The following is a description of a gene set: Genes predicted to be targets of miRBase v22 microRNA hsa-miR-6783-5p in miRDB v6.0 with MirTarget v4 prediction scores > 80 (high confidence targets). from publication Chen Y, Wang X (PMID 31504780) Human Gene Set: MIR6783_5P species: Homo sapiens, and this is the list of marker genes: COL5A2, CSRNP2, PCDHA13, CEP162 (centrosomal protein 162), ASAP1, PCDHA5, RNF34, SLC45A3, PCDHA10, ARL3, PCDHA8, CCL2, IPO8, ZMYM4 (zinc finger MYM-type containing 4), GLYATL3, DLK1, KCNIP2, DGKA, ZNF483, SLC17A7, CADM2, CRABP1, ARRB1, STAU2, NTRK2, KIF21B, MID2, L3MBTL1, ZFAND1, PYGO2, APLP1, PCDHA6, POGZ, PTCHD3, PRH2, PCP4L1, MAGED1, MIEN1, TMEM87A, OTULIN (NCBI Gene Id 90268), PTPN14, LRRC8C, RNF41, PLXDC2, PDE4A, SCN3B, BCL7A, SORCS2, PCDHA12, SLITRK1, NR2F2, ANKRD62, GSPT1, ANKRD44 (ankyrin repeat domain 44), LGALS13, THAP1, NDN, SNX9, CD164, AMOTL2, TGFB3, MBD6, SINHCAF, MAGI1, POU2F1, STK4, RAB5B, RNFT2, LRPPRC, DCAF12, GALNT3, ZNF566, USB1 (U6 snRNA biogenesis phosphodiesterase 1), PIP4P1, FAM120C, ZNF214, KAT6A, G2E3, PCDHA1, OLFML1, PPP1R3A, ARCN1, ZNF800, CLIC4, STAP1, POLR1G, RSPH6A, LENG8, BCL2L11, PAIP2B (NCBI Gene Id 57218), THRAP3, PCDHA11, CNNM3, PLD5, ANGPTL3, PCDHAC2, MINK1, PGR, DRC3, WTAP, GK5, OAS2, ATF7, TENM2, OLR1 (NCBI Gene Id 4973), ADGRL3, AGAP1 (NCBI Gene Id 22851), ARL6IP6, JCAD, FKBP7, CD300E, NFIB, ADAMTSL5, EPYC, ANP32A, KIAA0232, SEMA5A, PCDHA2, AGTR2, TMEM64, ZMYM2, POU3F1, ACVR1C, ADRA1D, LARP1, KMT2A, ARHGAP32, ASH1L, RRP15, RFK, TYR, PLEKHH2 (pleckstrin homology, MyTH4 and FERM domain containing H2), PROX1, GRIA4, PCDHA4, EPHA3, IKZF4, KCTD5, TERB2, TARBP1, AAK1, CHD8, DLGAP1, VPS72, TSPYL1, ATXN7L3B, PCDHAC1, LCE2D, RAB7A, SAR1A, SYNC, SHROOM2, PCDHA7, PRORP, PCDHA3, CLVS1, EFNA5